Given this list of marker genes PRKN, HCRT, SH2B3 (SH2B adaptor protein 3), SATB1, PI4K2A, ATP8B1, DNAJC30, ELN, GTF2I, DCTN1, STUB1, PINK1, TMEM270, SYNJ1, LIMK1, CLIP2 (NCBI Gene Id 84805), ABCB4, UCHL1, GNS, KMT5B, DNAJC6, NEUROG1, GALNT2, BUD23, BAZ1B, EIF4H, JAK2, HLA-DQB1, GTF2IRD2, PARK7, PRR12, CPOX, HTT, SLC12A3, TP53, CRY1, FBXO11, NR1H4, MEN1 (menin 1), VPS13C, SLC25A13, KAT6A, ATP7B, VPS37D, CHD8, GTF2IRD1, LRRK2, ABCB11, MPL, ZNF365, SNCA, NOL3, CALR, TUBB3, HMBS, TBL2, FKBP6, FARS2, PDE2A, PODXL, NAGS, HTRA2, PRNP, RFC2, NCF1, CLCNKB, HEXB, TET2, METTL27, SLC2A3, YY1, STX1A, HLA-DRB1, here is a description of the gene set: Insomnia studied in species Homo sapiens Persistent difficulty initiating or maintaining sleep. Human Gene Set: HP_INSOMNIA